The following is a description of a gene set: Genes predicted to be targets of miRBase v22 microRNA mmu_miR_27a_5p in miRDB v6.0 with MirTarget v4 prediction scores > 80 (high confidence targets). species: Mus musculus Mouse Gene Set: MIR_27A_5P from publication Chen Y, Wang X (PMID 31504780), and this is the list of marker genes: Pcdh20, Tbcel, Bach1, Sap18, Cyp2f2, Rpusd2, Gfpt2, Cdk17, Adcy1, Eif5, Mrpl19 (NCBI Gene Id 71577), Hectd2, Skil, Uba6, Tmem45a2, Tshz3, Sap18b, Zfp963, Usp18, Btf3, Rlim, Elavl1, Krt71, Rabgap1, Tmem9b, Npm1, Morc3, Hecw2, Dlg2, Arcn1, Il2, Moxd1, Gsdma